Given this list of marker genes Dnajc10, Smim6, Tnnt3, Tnni3, Mrln, Setmar, Tor1aip1, Dnajc9, Agrn, Pln, Myh6, Ublcp1, Ahsa1, Sirt1, Pfn1, Dnajb2, Msh3 (mutS homolog 3), Aldob, Msh2, Dnajb11, Fgf10, Dhx9 (DExH-box helicase 9), Ltf, Vmp1 (NCBI Gene Id 78510), Pxk, Chtop, Atp5if1, Atp1b2, Hspa2, Tnnc1, Pot1b, Ppif, Vcpkmt, Tmem64, Atp2a1, Nr3c2, Sln, Tpm2, Tsc1, Sumo1, Plscr1, 1810037I17Rik, Pot1a, Msh6, Zfas1, Tor1aip2, Dnajc24, Strit1, Tlr9, Zc3hav1, Atp1b3, Atp1b1, Dnajb1, Pfn2, Casr, Rgn, Myl4, Hnrnpu, Tnnt2, Oxa1l, Ssbp1, here is a description of the gene set: Mouse Gene Set: GOBP_REGULATION_OF_ATP_DEPENDENT_ACTIVITY Any process that modulates the rate of an ATP-dependent activity. species: Mus musculus